The following is a description of a gene set: Reactome Pathway: PTK6 promotes HIF1A stabilization HBEGF-stimulated formation of EGFR heterodimers with GPNMB triggers PTK6-mediated phosphorylation and stabilization of the hypoxia inducible factor 1 alpha (HIF1A) under normoxic conditions. This process depends on the presence of a long non-coding RNA LINC01139 (LINK-A). studied in species Homo sapiens part of: Signaling by PTK6, and this is the list of marker genes: HBEGF, PTK6, LRRK2, GPNMB, EGFR, LINC01139, HIF1A